The following is a description of a gene set: from publication He P, Lim K, Sun D, Pett JP, Jeng Q, Polanski K, Dong Z, Bolt L, Richardson L, Mamanova L, Dabrowska M, Wilbrey-Clark A, Madissoon E, Tuong ZK, Dann E, Suo C, Goh I, Yoshida M, Nikolić MZ, Janes SM, He X, Barker RA, Teichmann SA, Marioni JC, Meyer KB, Rawlins EL (PMID 36493756) Human Gene Set: HE_LIM_SUN_FETAL_LUNG_C4_ACTIVATED_NK_CELL Activated NK species: Homo sapiens, and this is the list of marker genes: TNFRSF18, FEZ1, NDFIP2, RRS1, MIR155HG, STARD4, CD82, ICAM1 (NCBI Gene Id 3383), BCL2L11, NME1, GFOD1, UCK2, TMEM120A, NEK6, CRTAM, DOT1L, PHLDA1, FCRL3, STX11, BCL2A1, BCL2L1, RAMP1, TNFRSF9, FABP5, TNFRSF4, SPATA13, TSPAN17 (tetraspanin 17), SNX8, FAM3C, PIM3, SFXN4, CD72, IRF8, MAP1LC3A, HAVCR2 (hepatitis A virus cellular receptor 2), TRAF1, RRP9, SLAMF7, TIMM8A, LIM2, RNF19A (ring finger protein 19A, RBR E3 ubiquitin protein ligase), EGR2, HYOU1, PRR5L, PUS1 (NCBI Gene Id 80324), PNO1, MRTO4, APLP2